The following is a description of a gene set: Mouse Gene Set: GOBP_NEGATIVE_REGULATION_OF_EPITHELIAL_CELL_PROLIFERATION_INVOLVED_IN_PROSTATE_GLAND_DEVELOPMENT species: Mus musculus Any process that decreases the rate, frequency or extent of epithelial cell proliferation that contributes to the progression of the prostate gland over time., and this is the list of marker genes: Cdkn1b, Serpinf1, Stk11, Nkx3-1, Apc (APC, WNT signaling pathway regulator), Wdr77, Eaf2 (NCBI Gene Id 106389)